Given this list of marker genes MRM3, TRMT61A, NSUN2, NOP2, TRMT61B, TFB1M, NSUN5P2, TRMT10B, FTSJ3, TRDMT1, NSUN5P1, TRMT10A, TRMT5, METTL15, LCMT2, TRMT2B, TRMT13, TRMT1L, TARBP1, METTL6 (methyltransferase 6, tRNA N3-cytidine), METTL1, CMTR1, METTL16, NSUN6, TRMT10C, TFB2M, TGS1, FDXACB1, TRMT12, EMG1, TRMT11, METTL5, PCIF1, ZCCHC4, NSUN4, TRMT1, MRM2, THUMPD3, NSUN5, MEPCE, TRMT2A, MRM1, NSUN3 (NCBI Gene Id 63899), TRMT9B, RNMT, METTL4, DIMT1, METTL25B, THUMPD2, TYW3, FBL, TRMO, BUD23, METTL14, HENMT1, FBLL1, CMTR2, SPOUT1, TRMT44, METTL15P1, METTL2A, BCDIN3D, TMT1A, ALKBH8, METTL3, METTL2B, METTL8, FTSJ1 (FtsJ RNA 2'-O-methyltransferase 1), here is a description of the gene set: Human Gene Set: GOMF_RNA_METHYLTRANSFERASE_ACTIVITY Catalysis of the transfer of a methyl group from a donor to a nucleoside residue in an RNA molecule. studied in species Homo sapiens